Given this list of marker genes MLXIPL, ADORA1, MIR132, DGAT1, ABCD1, SIRT1, ACACB, POLD1 (NCBI Gene Id 5424), GPAM, NR1H4, GOT1, XBP1 (NCBI Gene Id 7494), DGAT2, APOE, ENPP7, INS, PRKAA2, PRKAA1, here is a description of the gene set: studied in species Homo sapiens Any process involved in the maintenance of an internal steady state of fatty acid within an organism or cell. Human Gene Set: GOBP_FATTY_ACID_HOMEOSTASIS